Given this list of marker genes TREH, CLPS, CEL, PIR (pirin), PNLIPRP1, PNLIPRP2, GUCA2A, AMY1B, ALPI (NCBI Gene Id 248), LIPF, SI, CHIT1, PNLIP, AMY1C, LCT, GUCA2B, GUCY2C, MGAM, CHIA, AMY2A (amylase alpha 2A), PNLIPRP3, AMY2B, AMY1A, here is a description of the gene set: Reactome Pathway: Digestion Dietary carbohydrates, fats, and proteins must be broken down to their constituent monosaccharides, fatty acids and sterols, and amino acids, respectively, before they can be absorbed in the intestine.<br>Dietary lipids such as long-chain triacylglycerols and cholesterol esters are hydrolyzed in the stomach and small intestine to yield long-chain fatty acids, monoacylglycerols, glycerol and cholesterol through the action of a variety of lipases, and are then absorbed into enterocytes.<br>Carbohydrates include starch (amylose and amylopectin) and disaccharides such as sucrose, lactose, maltose and, in small amounts, trehalose. The digestion of starch begins with the action of amylase enzymes secreted in the saliva and small intestine, which convert it to maltotriose, maltose, limit dextrins, and some glucose. Digestion of the limit dextrins and disaccharides, both dietary and starch-derived, to monosaccharides - glucose, galactose, and fructose - is accomplished by enzymes located on the luminal surfaces of enterocytes lining the microvilli of the small intestine.<br>Dietary protein is hydrolyzed to dipeptides and amino acids by the action of pepsin in the stomach and an array of intestinal hydrolases. All of these enzymes are released in inactive (proenzyme) forms and activated by proteolytic cleavage within the gastrointestinal lumen (Van Beers et al. 1995; Yamada 2015). part of: Digestion and absorption species: Homo sapiens